The following is a description of a gene set: studied in species Homo sapiens Any process that activates or increases the frequency, rate or extent of protein acetylation. Human Gene Set: GOBP_POSITIVE_REGULATION_OF_PROTEIN_ACETYLATION, and this is the list of marker genes: BMAL1, DIP2B, KAT5, FAM161A, CEP295 (centrosomal protein 295), DIP2A, XBP1